The following is a description of a gene set: Any process that increases the rate, frequency or extent of cGMP-mediated signaling. species: Homo sapiens Human Gene Set: GOBP_POSITIVE_REGULATION_OF_CGMP_MEDIATED_SIGNALING, and this is the list of marker genes: NPPA, RUNDC3A, GUCA1ANB-GUCA1A, NPR1, KDR, NPPC, ADORA2B, GUCA1A